Given this list of marker genes EPX, MIRLET7C, DLL1, MIR194-1, FCGR2B, VSIR (V-set immunoregulatory receptor), MIR98, IL12B, TYROBP, AGER, PDCD1LG2, IL23A, MIR106A, TRIB2, IL23R, IDO1, THBS1, TNFRSF21, JAK3, FOXP3, CD274, PRG2, LILRB4, LILRB1, BTK, here is a description of the gene set: Any process that stops, prevents, or reduces the frequency, rate, or extent of interleukin-10 production. Human Gene Set: GOBP_NEGATIVE_REGULATION_OF_INTERLEUKIN_10_PRODUCTION studied in species Homo sapiens